Given this list of marker genes KRAS, NEDD9, STK17B, ERI1, MDFIC, HLA-DMB, GADD45A, CSTB, USB1 (U6 snRNA biogenesis phosphodiesterase 1), CXCL6, MATK, ATP6V0B, NRROS, STX7 (syntaxin 7), PNRC1, NAMPT, SNX18, DEF8, HPCAL1, LPAR4, PAPSS1, GABRD, GSS, NOP10, C5orf47, PTPN18, RNF103, PNPO, KAT2B, SDCBP, NELFCD, SQLE, SGMS1, H1-2, HCAR2, RPIA, SDC3, RPA1, CTSD, ENTREP3, SERPINB6, RPL7L1, SEPTIN9, TIFA, DOCK8, DLAT, DUSP22, JUNB, RBM7, POT1, IER5, VPS26B, TNFRSF1A, ELK3, CCL2, SOCS6, CXCL10 (C-X-C motif chemokine ligand 10), POLH, QDPR, PIAS2, NIT2, NDUFS2, JUN, RCBTB2, TPCN1, EVI2A (ecotropic viral integration site 2A), SLCO1C1, MRTO4 (MRT4 homolog, ribosome maturation factor), NCK1, TFDP1, SEC11A, MRPS2, CHURC1, RIN2, ABCB10, RASGRP1, CHIC2, TMCC2, NUMB, TPD52, RBP3, TMED7, SSBP4, PIM3, AURKA, DCUN1D5, ARHGEF3, LRP6, CCL13, RHBDD1, CASP6, FAM174A, TMEM14C, DCPS (NCBI Gene Id 28960), LCN8, IL12A, TIMM29, KRCC1, RILPL2, CTSV, PLBD1, HSD17B7, PRIM2, NDUFA9, PCLAF, TMEM33 (NCBI Gene Id 55161), TVP23A, NLRP3, SPRED1, SMIM11, IL1A, BMI1, RPF2, OLR1, TRAF6 (TNF receptor associated factor 6), ACTL6A, RHOB, PPTC7, PRXL2B, CLOCK, PRKACA, PRKD3, DLST, MICU1, IDH3A, VRK2, XPO7, REL, SREK1IP1, FOXJ3, TFPI, INTS11, FGL1, AP4M1, SLC25A25, HCCS, CLCF1, ARHGAP39, CCDC159, PIK3C3, MSR1, CEP68, CSF1, YWHAH, PCBD2, ACTR3, ACYP1, VGLL1, PANK1, ZBTB2, RBM12, COL4A6, MYL11, HDAC3, XPR1, MRAS, FTH1, APC, ACLY, BMP5, RELA (NCBI Gene Id 5970), TFF1, TRABD, MAPK1, OR10J5, F3, WDR20, STAC2, PTGER4, MKNK1, CISH, KCNMB2, BMP6, LDLR, SACM1L, GNG2, PTPRU, SH3BGR, HIP1, MAFF, ARL1, OLFML3, ANP32B, AVL9, ERRFI1, PDE4B (phosphodiesterase 4B), EMB, PLEKHF2, ZYG11B, RAD51AP1, CAMKK1, TESMIN, SLC35B3, MCUB, ETS2 (NCBI Gene Id 2114), SVIL, HSD17B12, ANXA6, OAZ2, here is a description of the gene set: Human Gene Set: GSE17721_POLYIC_VS_GARDIQUIMOD_1H_BMDC_DN from publication Amit I, Garber M, Chevrier N, Leite AP, Donner Y, Eisenhaure T, Guttman M, Grenier JK, Li W, Zuk O, Schubert LA, Birditt B, Shay T, Goren A, Zhang X, Smith Z, Deering R, McDonald RC, Cabili M, Bernstein BE, Rinn JL, Meissner A, Root DE, Hacohen N, Regev A (PMID 19729616) mouse primary BMDCs were stimulated with tlr ligands and gene expression changes were profiled on Affymetrix arrays studied in species Homo sapiens Genes down-regulated in comparison of dendritic cells (DC) stimulated with poly(I:C) (TLR3 agonist) at 1 h versus DC cells stimulated with Gardiquimod (TLR7 agonist) at 1 h.